Given this list of marker genes COL12A1, SSPN, PECR, ZNF423, SOBP, RAX, RORA, DSPP, CLK2, FEV, GNA13, HOXC4, NLGN2, EN1, SSBP3, EDA, LEMD1, ARID3B, WNT7A, CYLD, SULF2, IER3, SYTL5, SRSF7, BNC2, NPR3, TRIM24, PRDM1, PITPNC1 (phosphatidylinositol transfer protein cytoplasmic 1), STX7, INPPL1, JHY, SMAD6, ADAM11, PPP1R1B, KAT6B, TMEM178A, LRRTM1, DMD (dystrophin), ST8SIA3, SEMA5B, SULF1, MYT1, ETNK1, FZD7, CHST8, OPRM1, CGA, BAZ1A, SLC24A2, BHLHE41 (basic helix-loop-helix family member e41), OSBPL8, OSR2, RGS8, FLOT1, MAP1B, CALN1, RORB, PROK2, MS4A1, ELMO1, DPH1, LMO4, TP63, VAMP8, TBC1D20, HHIP, SP8, C1orf122, PURA, MMP27, YRDC, MAB21L1, MID1, NKX6-1, NEO1, KLF14, TFAP2D, KCNK2, SRPK2, RPA2, TRPM8, ZRSR2, PRR34, PIK3R3, TNRC6A (trinucleotide repeat containing adaptor 6A), HRK, TBX19, LRRC4, APPL2, LUC7L3, PPM1E, DLC1, WNT8B, SEMA3A, MLLT10, NOTCH2NLA, KCTD15 (NCBI Gene Id 79047), HOXC12, ADD3, ZEB2, IRX6, SLITRK2, ITGA8, SEZ6L, BACE2, PAX3, PRKAR2A, RREB1, ALKBH5, IRX5, TYR, MYF6, TFAP2A, TMEM179, KRT23, DLL4, SLC6A5, BLMH, MARCKS, ZBTB20, FAM193B, NOTCH2, SALL3, EDC4, CDH10, ARHGEF10L, DIXDC1, LBX1, ELP4 (elongator acetyltransferase complex subunit 4), XYLT2, FIGN, RUNX1T1, FZD10, PDZRN4, NOVA1, LRFN5, NFYA, TAAR5, ADAMTS10, ITPR3, CLRN1, TLE4, LMX1A, OARD1, FIP1L1, HERPUD2, LRRC15, NRL, TMEM169, CD36 (NCBI Gene Id 948), LDB2, MTSS1, MBNL1, PRDM8, IRX4, DHX38, NDST4, PACSIN3, SHOX2, RTCB, PRRX1, TXNL4B, ARHGAP44, PRKAB1 (NCBI Gene Id 5564), UBR3, DMRTA1, SOHLH2, TBR1, PCNT, RAPGEFL1 (Rap guanine nucleotide exchange factor like 1), SH3BGRL2, TMIGD1 (transmembrane and immunoglobulin domain containing 1), GNAO1, KALRN, TAL1, BMAL1, RTN4RL1, ELF4, H2AZ1, IMMP1L, LMO3, CDYL, ATXN7L1, TFDP2, SUCLG2, NREP, HESX1, TECTA, MOSMO, NABP2, JDP2, here is a description of the gene set: Genes having at least one occurrence of the highly conserved motif M61 YTAATTAA in the regions spanning 4 kb centered on their transcription starting sites. This matches the LHX3 transcription factor binding site V$LHX3_01 (v7.4 TRANSFAC). Comprehensive identification of all functional elements encoded in the human genome is a fundamental need in biomedical research. Here, we present a comparative analysis of the human, mouse, rat and dog genomes to create a systematic catalogue of common regulatory motifs in promoters and 3' untranslated regions (3' UTRs). The promoter analysis yields 174 candidate motifs, including most previously known transcription-factor binding sites and 105 new motifs. The 3'-UTR analysis yields 106 motifs likely to be involved in post-transcriptional regulation. Nearly one-half are associated with microRNAs (miRNAs), leading to the discovery of many new miRNA genes and their likely target genes. Our results suggest that previous estimates of the number of human miRNA genes were low, and that miRNAs regulate at least 20% of human genes. The overall results provide a systematic view of gene regulation in the human, which will be refined as additional mammalian genomes become available. from publication Xie X, Lu J, Kulbokas EJ, Golub TR, Mootha V, Lindblad-Toh K, Lander ES, Kellis M (PMID 15735639) Human Gene Set: YTAATTAA_LHX3_01 species: Homo sapiens